The following is a description of a gene set: Neighborhood of UNG Human Gene Set: MORF_UNG species: Homo sapiens Neighborhood of UNG uracil-DNA glycosylase in the MORF expression compendium, and this is the list of marker genes: NHP2, HAT1, NDUFS3, MFAP1, CCT2, PSMB2, VBP1, ICE1, MAGOH, NSDHL, MRPL3, ATIC, COPS5 (COP9 signalosome subunit 5), EIF4G1 (eukaryotic translation initiation factor 4 gamma 1), CCT3, DDX1, HNRNPA3P1, PDCD6, CDK4, ATP5MC3, POP5, HSPA9, PPM1G, SET, HNRNPU, ATP5PF, SNRPA1, CCT5, HNRNPAB, SSBP1 (NCBI Gene Id 6742), HSPE1, PSMD7, MTHFD1, TUFM, GSPT1, NAA10, NDUFAB1, CDC23, RFC4, HCCS, RBM14, FEN1, KPNA2, MRPL19, RPA1 (replication protein A1), HNRNPA2B1, UTP18, POLR2I, EIF3B, CYCS (cytochrome c, somatic), MSH2, RAD23B, ALG8, DOCK3, PRMT1, C1QBP, G3BP1, BAZ1B, POLE3, BANF1, H2AZ1, PCNA, SOD1, SRSF1, PCLAF, TMEM106C, AIMP2, MRPS18B, HDAC2, AHSA1, KARS1 (NCBI Gene Id 3735), SEM1, TRIM28, UNG, VDAC1, NUDC